The following is a description of a gene set: studied in species Homo sapiens Broad neck Increased side-to-side width of the neck. Human Gene Set: HP_BROAD_NECK, and this is the list of marker genes: SVIL, MED12, TWIST1, COG1, PHGDH, POLE, HES7, RPS26, NF1, NUP88, DHX37, RAPSN, MEGF8, ZFX (zinc finger protein X-linked), BPTF, PSMD12, B3GLCT, FILIP1, RPS28, UBE2A, MAPRE2, FHL1, CCDC22, WNT7A, ZMYM2, SLC2A1, HYLS1, IGBP1, TOGARAM1, PPP1CB, TECPR2